The following is a description of a gene set: species: Homo sapiens Synthesis of PI Human Gene Set: REACTOME_SYNTHESIS_OF_PI, and this is the list of marker genes: CDIPT, CDS1, PITPNM1, PITPNM3, PITPNM2